Given this list of marker genes Opa1, Fdx1, Cox6b2, Slc8b1, Bdnf, Star, Bcl2, Akap1, Atpsckmt, Hspd1, Hsd3b1, Cibar1, Tmem70, Ptpn1, Lyn, Cyp11a1, here is a description of the gene set: Mouse Gene Set: GOCC_MITOCHONDRIAL_CRISTA Any of the inward folds of the mitochondrial inner membrane. Their number, extent, and shape differ in mitochondria from different tissues and organisms. They appear to be devices for increasing the surface area of the mitochondrial inner membrane, where the enzymes of electron transport and oxidative phosphorylation are found. Their shape can vary with the respiratory state of the mitochondria. species: Mus musculus